Given this list of marker genes Psmc6, Gli3 (GLI-Kruppel family member GLI3), Numb, Psmd7, Tuba1c, Prkacb, Tubb4a, Psmb4, Prkar1b, Psmc5, Psmb6, Psmc3, Tubb4b, Adcy8, Tuba1b, Ift172, Psmb5 (proteasome (prosome, macropain) subunit, beta type 5), Smo, Prkaca, Psma2, Adcy7, Psma4, Psmb7, Adcy5, Psma3, Psmc4, Rps27a, Tuba1a, Psma6, Ift88, Ubb, Gpr161, Psma1, Wdr35, Ttc21b, Psmc2, Psmd1, Tuba3b, Psmd6, Psma7, Tuba4a, Tubb6, Psmc1, Fuz, Tubb2b, Psmd13, Psma5, Csnk1a1, Ift57, Cul1, Mks1, Psmd12, Prkar2b, here is a description of the gene set: Reactome Pathway: Hedgehog 'off' state part of: Signaling by Hedgehog electronically inferred by orthology from the curated human pathway studied in species Mus musculus This event has been computationally inferred from an event that has been demonstrated in another species.<p>The inference is based on the homology mapping from PANTHER. Briefly, reactions for which all involved PhysicalEntities (in input, output and catalyst) have a mapped orthologue/paralogue (for complexes at least 75% of components must have a mapping) are inferred to the other species.